The following is a description of a gene set: The orderly movement of an astrocyte, a class of large neuroglial (macroglial) cells in the central nervous system, the largest and most numerous neuroglial cells in the brain and spinal cord. studied in species Mus musculus Mouse Gene Set: GOBP_ASTROCYTE_CELL_MIGRATION, and this is the list of marker genes: Arhgef7, Mmp14, Apcdd1, Hexb, Ccl3, Nr2e1, Gpr183 (G protein-coupled receptor 183), Ccl2, Ccr2, Scrib, Ccl12